Given this list of marker genes PAPSS1, DGKH, AMIGO2, MLF1, ARL5B, SP100, C14orf28, DNAAF9, ZNF449, GPC6, WASHC5, CPSF6, GRIA4, MSR1, YPEL1, KRT4, ZIC5, CHRNA5, TRIP11, GTF2A1, RPF2, ADAMDEC1 (ADAM like decysin 1), PARPBP, C5orf34, MFSD1, GPM6A, ZNF674, UBXN2B, NBEA, ZZZ3, HDX, RNF38, GJB7, STK17A, CACNB2, CPED1, LTV1, SLC22A10, KPNA1, SPTLC1, OXR1, DUSP16 (NCBI Gene Id 80824), ST8SIA1, TET1, RBFOX2, TMEM167B, RAB10, ZBTB44, ODAM, MAP3K7CL, here is a description of the gene set: Human Gene Set: MIR3923 studied in species Homo sapiens Genes predicted to be targets of miRBase v22 microRNA hsa-miR-3923 in miRDB v6.0 with MirTarget v4 prediction scores > 80 (high confidence targets). from publication Chen Y, Wang X (PMID 31504780)